The following is a description of a gene set: Mouse Gene Set: MIR_183_5P studied in species Mus musculus Genes predicted to be targets of miRBase v22 microRNA mmu_miR_183_5p in miRDB v6.0 with MirTarget v4 prediction scores > 80 (high confidence targets). from publication Chen Y, Wang X (PMID 31504780), and this is the list of marker genes: Mfsd6 (major facilitator superfamily domain containing 6), Nr3c1, Haus2, Vdac1, Prkch, Atl2, Cep97, Slc35a1, Frmd6, Mbnl1, Slitrk1, Pias2, Arhgap18, Gng5, Zdhhc6, Spink13, Atf2, Irs1, Aldh6a1, Gja5, Mtmr6, Atp2b4, Kcng4, Ttc7b, Mphosph8, Arhgef18, Map7d2, Akap7, Garre1, Cyyr1, Ikzf5, Chd2, Zfyve26, Alg5, Scyl3, Arhgap21, Qrfpr, Slc25a20, Smc3 (NCBI Gene Id 13006), Zeb1, Krtap31-1, Celf2, Potefam3b, Map3k2, Gng4, Fcho2, Zbtb34, Rab21, Ppp2ca, Mapk4, Terf1, Ezr (NCBI Gene Id 97496), Kcnk10, Rora, Npc2 (NCBI Gene Id 67963), Arpp19, Krtap3-3, Fndc3b, Osbpl8, Cd3d, Tpm1, Mapk8ip1, Baz1b, Idh2, Gmfb, Zfpm2 (zinc finger protein, multitype 2), Rcn2, Atm, Tmsb4x, Dync1i1, L3mbtl3, Pam, Bbof1, Abraxas2, Epha4, Pdcd4, Nfyc, Rfx3, Erp44, Grem2, Cnot6l, Pdcd6 (programmed cell death 6), Shisa7, Cfl2, Sema3e, Erich5, Slain1, Cep170b, Unc13b, Zfp451, Wfdc8, Tmed7, Rpia, Kif13a, Ctdspl, Map3k4, Lhfpl2, Nmrk1, Nrp2, Ist1, Potefam3e, Mal2, Rab8b, Ppm1e, Ppp2cb, Srsf2, Pfn2, Birc6, Potefam3a, Cacnb4, Dgcr2, Pex19, Ajap1, Pnoc, Or8b53, Nufip2, Enah, Ankrd13c, Csmd1, Neu3, Bach2, Dmxl1, Spry2, Psen2, Ptpn4, Cnr2, Nfe2l1, Rala, Daam1, Zfp622, Epdr1, Gjd2, Ppp2r5c, Flrt3, Itgb1, Ppp2r2a, Foxn2, Erbin, Kif2a, Clcn3, Atrn, Gstt3, Noc3l, Kcnk2, Rabgap1l, Mrps27, Tmpo, Srek1ip1, Pla2r1, Lck, Samd4